The following is a description of a gene set: Human Gene Set: GSE13738_RESTING_VS_BYSTANDER_ACTIVATED_CD4_TCELL_UP Genes up-regulated in comparison of resting CD4 T cells versus bystander activated CD4 T cells. studied in species Homo sapiens from publication Bangs SC, Baban D, Cattan HJ, Li CK, McMichael AJ, Xu XN (PMID 19201849) There is much evidence that T cells may be activated via mechanisms which act independently of direct TCR ligation. Despite this, the question of whether such forms of ‘bystander’ T cell activation occur during immune responses is hotly debated. To address some outstanding questions, we set up an in vitro system within which to analyse bystander T cell activation in human T cells, in the absence of the possibility for TCR cross-reactivity. In addition, we have investigated the genetic, phenotypic, and functional characteristics of bystander activated T cells. Here, we show that bystander T cell activation is, indeed, observed during a specific immune response, and that it occurs preferentially amongst CD4+ memory T cells. Furthermore, bystander activated T cells display a distinct gene expression profile. The mechanism for bystander T cell activation involves soluble factors, and the outcome is an elevated level of apoptosis. This may provide an explanation for the attrition of T cell memory pools of heterologous specificity during immune responses to pathogens such as viruses., and this is the list of marker genes: TIGD7, BCO2, FGF9, TNN, MED13L, ADNP2, TARBP1, PNRC2, LEPROTL1, CALHM1, TCF7 (NCBI Gene Id 6932), LINC01138, MARCKSL1, FAM117B (family with sequence similarity 117 member B), ZNF550, NAA16, PTPRK, DCAF8, SERINC5, PAN2, STK17A, IGF1R, SPN, RAB27B, SSX2IP, ZNF564, ATF7IP, LARGE-AS1, LAMTOR4, MIR600HG, ATXN7 (ataxin 7), NELL2, ERN2, TRIM44, RBM26, HERC1, CHMP3, RUNDC3A, CELF1, NEK2-DT, SPNS1, ONECUT3, NKAPL, ATM (NCBI Gene Id 8068), TGM4, AMIGO1, USP27X, NDRG2, FAM13B, LINC00326, LMF1, ERBIN, PTAR1, TSHZ1, MAGEB2, THRB, RADX, KMT2C, DCAF12L1, ZNF548, TGFBR2, TNRC6B, SNRPN, PLCL2, CHD3, ZNF493, TANC2, RPRD2, KRAS, PRUNE1, CLIP4, FOXJ3, GARRE1, ZNF830, HELZ, RXRB, VPS37D, SLC5A2, IL6ST, SAMD4B, ARHGAP32, TMOD4, CAMK4, MAML2, TUT7, CCNI, TMOD2, ZBTB5, SLC40A1, ANKFN1, PIK3IP1, MLXIPL, PRSS58 (serine protease 58), LINC02092, ZBTB44, SCAF11, CHCHD7, OPRPN, TUG1, LCOR, TMIGD2, ZBTB20, CCDC18-AS1, THEMIS (NCBI Gene Id 387357), ZC3HAV1, TRO, GPRASP2, UNKL, GVINP1, TMEM106B, LINC01949 (long intergenic non-protein coding RNA 1949), GIMAP7, SCML4, BICC1, PRKAA2, MATN1-AS1, APBA2 (amyloid beta precursor protein binding family A member 2), ANXA2R, CREBRF, COA8, DEFB123, VNN2, SPEN-AS1, TENM1, CHML, COA1, SELL, PRRC2B, MLLT10 (MLLT10 histone lysine methyltransferase DOT1L cofactor), TSPYL4, STUB1-DT, OR7E19P, BCL9, PLAG1, PRKACB, ABLIM1, RBM27, C9orf72, STAG2, AGO4, AMN1, ROBO3, FHIP2B, NXF1, GPR18, GABPB1-AS1, NR2C2, VWA1, EDEM3, LRRC8D, EIF1B-AS1, PLAC9, CGN (NCBI Gene Id 57530), ENGASE, PXYLP1, PREPL (NCBI Gene Id 9581), KLRK1, TRIM23 (NCBI Gene Id 373), TSC22D1, FBXL3, ZFTRAF1, PTPRF, ZNF397, PLA2G4F, PTK2, JADE1, MGAT4A, LRRC37A2, RBM26-AS1, ACSS1, TDRD6, SHISA2, UBN2, LINC00685, UBE2CP4, FILIP1, PECAM1, RCAN3, CCDC13, IRAG2 (NCBI Gene Id 650574), PDCD4-AS1 (PDCD4 antisense RNA 1), BOLL, KAT6A (NCBI Gene Id 7994), PARP8, GIMAP4, LINC01550, PLSCR2, CPT1C, SARAF, ZNF711, ADAMTS6, EDAR, FAM161B, PSIP1